The following is a description of a gene set: species: Mus musculus Mouse Gene Set: GOBP_DETECTION_OF_TEMPERATURE_STIMULUS_INVOLVED_IN_THERMOCEPTION The series of events in which a temperature stimulus is received and converted into a molecular signal as part of thermoception., and this is the list of marker genes: Opn4, Grik2, Rho, Wdr47, Trpv1